Given this list of marker genes Spag17, Cfap69, Spag16, Hydin (HYDIN, axonemal central pair apparatus protein), Spef1, Spag6l, here is a description of the gene set: Mouse Gene Set: GOCC_AXONEMAL_CENTRAL_APPARATUS Part of the 9+2 axoneme, that occurs in most motile cilia, consisting of the pair of two single central microtubules and their associated structures which include the central pair projections, the central pair bridges linking the two tubules, and the central pair caps which are attached to the distal or plus ends of the microtubules. species: Mus musculus